The following is a description of a gene set: Enables the transfer of a solute or solutes from one side of a membrane to the other according to the reaction: carbohydrate(out) + H+(out) = carbohydrate(in) + H+(in). species: Homo sapiens Human Gene Set: GOMF_CARBOHYDRATE_PROTON_SYMPORTER_ACTIVITY, and this is the list of marker genes: SLC45A1, SLC45A3, SLC2A9, SLC45A2, SLC45A4, SLC2A10, SLC17A5